The following is a description of a gene set: from publication Chen Y, Wang X (PMID 31504780) species: Homo sapiens Human Gene Set: MIR887_3P Genes predicted to be targets of miRBase v22 microRNA hsa-miR-887-3p in miRDB v6.0 with MirTarget v4 prediction scores > 80 (high confidence targets)., and this is the list of marker genes: PLD2, CCPG1, TCTN3, ATP2B2, CNPY2, CASK